Given this list of marker genes APC, WAS, FN1, PLA2G4A, ABCD3, CD55, TMPRSS6, ZNF699, STK11, CLPX, SLC12A3 (solute carrier family 12 member 3), FOXP3, HLA-DQB1, ALAS2 (NCBI Gene Id 90735), FGF23, GALNT2, CLCNKB, HBB, COL2A1, EIF2AK3, DIAPH1, COL7A1, KCNE1, CASP10, HLA-DQA1, FASLG, MMP1, KCNQ1, ALG2, NAA10, ATRX, ELF4, FAS, here is a description of the gene set: Human Gene Set: HP_IRON_DEFICIENCY_ANEMIA Iron deficiency anemia studied in species Homo sapiens